The following is a description of a gene set: EBV EBNA3C to cell cycle G1/S. Pathway ID: N00484. Pathway type: Pathogen. Pathway class: nt06165 Epstein-Barr virus (EBV). Human Gene Set: KEGG_MEDICUS_PATHOGEN_EBV_EBNA3C_TO_CELL_CYCLE_G1_S_N00484 Pathway Definition from KEGG: EBNA3C -> SKP2 -> RB1 // E2F species: Homo sapiens, and this is the list of marker genes: RB1 (NCBI Gene Id 92728), E2F1, E2F3, SKP2, E2F2